Given this list of marker genes Ace2, Clic5, Dpy19l2, Zfp456, Ppme1, Krtap13 (NCBI Gene Id 16699), Acbd6, Peli1 (pellino 1), Trp53inp2, Fev, Ednrb, Sp1, Dagla, Stx5a, Ccdc177, Fem1c (NCBI Gene Id 67174), Mtarc1, Mcm7, Prl7b1, Trappc2, Ldlr (NCBI Gene Id 16835), Nampt, Bcat1, Cish, Capn12, Golga7b, Cenpq, Bbln, Rnf39, Tshz3, Arid4a, Apmap, Ptgir, Fam117a, Slc35a2, Abcg4, Map4k1, Ddx19b, Frmpd3, Alx4, Tspan18, Zfp408, Krt31, Osbpl7, Syce2, Tlk2, Entrep2, Dcaf12, Cramp1, Dpf2, Aqp4, Htra3, C1qtnf3, Ilk, Ulk2, Atp6v0c, Pde6d, Pde8b, Acadm, Endod1, Dnajb4, Cyb561a3 (cytochrome b561 family, member A3), Slc8a1, Nfia, Sesn2, Shisa7, Sbno1, Fam221a (NCBI Gene Id 231946), Cgn (NCBI Gene Id 99764), Spire1, Asb15, Rab33b, Ankrd63 (ankyrin repeat domain 63), Ccdc3, Slc17a2, Foxn1, Hmgb2, Atp1b4, Elk1, Prr14l, Atxn1l, Gatad2b, Ptgdr, here is a description of the gene set: Genes predicted to be targets of miRBase v22 microRNA mmu_miR_30c_1_3p in miRDB v6.0 with MirTarget v4 prediction scores > 80 (high confidence targets). Mouse Gene Set: MIR_30C_1_3P species: Mus musculus from publication Chen Y, Wang X (PMID 31504780)